The following is a description of a gene set: species: Mus musculus Mouse Gene Set: REACTOME_TERMINATION_OF_O_GLYCAN_BIOSYNTHESIS Termination of O-glycan biosynthesis, and this is the list of marker genes: Muc13, Muc17, St3gal4, St6galnac4, Muc6, St6galnac3, St3gal1, Muc19, Muc15, Muc1, Muc20, Muc4, St6gal1, Muc16, St3gal2, Muc21 (mucin 21), Muc5ac, Muc5b, Muc2, St3gal3, St6galnac2